Given this list of marker genes Loxl2, Lox, Loxl1, Loxl3, Loxl4, here is a description of the gene set: studied in species Mus musculus Mouse Gene Set: GOMF_PROTEIN_LYSINE_6_OXIDASE_ACTIVITY Catalysis of the reaction: peptidyl-L-lysyl-peptide + H2O + O2 = peptidyl-allysyl-peptide + NH3 + hydrogen peroxide.